Given this list of marker genes Cbfb, Dsg1a, Ap3s1, Ankfy1, Larp4, Fcho2, Nherf1, Celf3, BC005537, Zfc3h1, Cadm2, Myo6, Sema5b, Fam210a, Ears2, Sec23ip, Ero1b, Rprd1a, Ddx3x, Rwdd4a, Klhl29, Naaladl2, Tcf24, Tmem154, Pira2, Col8a2, Slc2a13, Pik3r1, Fam120a, Rnf152, Depdc5, Gsdmc, Bcl11b, Agfg1, Dipk2b, Tmx1, Tob1, Nup85, 2310002L09Rik, C9orf72, Prdm15, Leap2, Traf6, Inpp4a, Rab10, Zfp872, Tent5a (NCBI Gene Id 320335), Ovol1, Med13, Pank3, Cnot6, Fat4, B4galt4, Cd300a, Daam1, Nanog, Rbm27, Gm7694 (predicted gene 7694), Asxl2, Impa1, Cdk6, Slco1a1, Deptor, Pcmtd2, Inpp4b, Mknk2 (MAP kinase-interacting serine/threonine kinase 2), Ptpdc1, Fuca2, Dcaf12l2, Kcnd3, Strip2, Ttll1, Sema3e, Alg5, Sgms1, Dok5, Fbxo38, Hoxd1, Psen2, Cd53, Ppp4r2, Mterf1b, Homez, Phactr2, Zmynd8 (NCBI Gene Id 99150), Xrn1, Tacc1, Ino80d, Impg1, Pde10a, Bmerb1, Nckap5, Rab35, Mpv17l, Asap2, Wnt11, Ubl3, Bbx, Eif5a2, Nr2f6, Phykpl, Krt12, Chordc1, Tnrc6c, Lcp2, Smg1, Idnk, Arhgap36, Mycs, Ramac, Klhl42, Tram1l1, Dlst, Lrba, Bnc1, Abhd13, Oprk1, Rfesd, Fcrla, Runx2, Hmbox1, Uqcc6, Dpysl2, S1pr1, Usp54, Zfp143, Pikfyve, Nolc1, Slc4a2 (NCBI Gene Id 20535), Rgs7bp, Clcn4, Zfx, Nt5e, Nfrkb, Ipmk, Elovl5, Zfp800, Tmem131, Gspt1, Pigv, Dcun1d5, Iqgap2, Slc27a2, Tmem33, Mcf2l, Mak, A130010J15Rik, Krtap19-3, Phf11d, Smad2, Phf3, Rhobtb3 (Rho-related BTB domain containing 3), Slc35f5, Rnf150, Ints2, Fut9, Tmem150c, Trp63, Zbtb41, Ikbip, Rb1cc1, Shld2 (NCBI Gene Id 75698), Cntn2, Srsf1, Zfp704, B3gnt5, Dennd1b, Hnrnph2, Secisbp2l, Tfr2 (NCBI Gene Id 50765), Ripor2, Lpin2, 3110040N11Rik, Zfp365, Mmut, Senp7 (SUMO1/sentrin specific peptidase 7), Slc40a1, Itgb6, Bach1, Tenm4, Rock1, Ppp3r2, Pak2, Kmt2d, Shoc2, Dicer1, Atad2b (ATPase family, AAA domain containing 2B), Irs4, Prtg, Golga4 (golgin A4), Iqgap1, Setbp1, St18, Rrp1b, Pdcd4, Crppa, Trim33, Foxn2, Tyw5, Homer1, Ndfip2, Stx17, Nucks1, Epm2aip1, Sertad2, Ctnnd1, Nlrp4c, Sun1, Onecut2, Galntl6, Snx10, Nsd2, Slitrk2, Snx12, Zfp654, 3110082I17Rik, Brd8, Sp1, Mettl17, Sec23a, Itpr1, Hus1, Stom, Usp28, Hsf2bp, Fmr1, Ppm1b, Ikzf2, Cotl1, Tmcc3, Ankle2, Ptchd1, Arhgef6, Agtpbp1 (NCBI Gene Id 76578), Grxcr1, Gpr155, Fam169a (family with sequence similarity 169, member A), Hs3st3a1, Lpgat1, Cdc42bpa, Birc3, Tnfrsf11b, Prkci, Oprm1 (NCBI Gene Id 18390), Ctps2, Il13 (interleukin 13), Zfp518a, Grk2, Nufip2, Fzd3, Npat, Txndc5, Zxdc, Rabgap1l, Dgki, Olfm1, Sgip1, Nprl3, Zbtb5, Errfi1, Tnrc6b, Kat6a, Mbd4, Bicd1, Ngf, Zfp131, Fubp1, Sar1a, Mob3b, Steap2 (six transmembrane epithelial antigen of prostate 2), Bmt2, Sirt1, Cnot2, Phc3, Atxn7, Ubfd1, Braf, Tgoln1, Lrrfip1, Cdkn1b, Rxfp2, Rc3h2 (ring finger and CCCH-type zinc finger domains 2), Phf20l1, Phka1, Fgfbp3, Dmrt2 (doublesex and mab-3 related transcription factor 2), Rbpj, Map2, Lurap1l, Foxg1 (forkhead box G1), Zfand4, Ptbp1, Perp, Manea, Itpripl2, Trip11, Pbx4, Ankrd7, Enah, Tead1, Fkbp14 (NCBI Gene Id 231997), Cbx6, Bcor, Zranb2 (NCBI Gene Id 99569), Col25a1, Psd3, Rbp3, Gphn, Tgfa (NCBI Gene Id 21802), Tent4b (NCBI Gene Id 70570), Kalrn, Cdc14b, Ctsc, Acadl, Vgll3, Ehmt1, Htr1f, Potegl, Dytn (dystrotelin), Ereg, Mos, Grb2, Trim24, Adam22, Tmem200c, Smad6, Rapgef6, Ccdc157, Myc, Atp2b4, Fgf10, Ccr1, Mex3b, Nbr1, Trmt1l, Rgs6 (regulator of G-protein signaling 6), Sapcd2, Or51e2, Zbtb24, Rsrp1, Frmd3, Plppr5, Gtf2h1, Mafk, 1700102P08Rik, Aggf1 (angiogenic factor with G patch and FHA domains 1), Mdga2, Prpf4b, Rfx3, Ncor1, Acbd5, Pcmtd1, Grm1, Tbx22, Nsmce4a, Gtf2a1, Dach1, Zic2, Phip, Cxcl9, Gm14322, Sephs1, Mblac2, Reps2, Nup54, Chrna1, Ncl (nucleolin), Slc25a51, Setd3, Ninl, Bmi1, Slmap, Pttg1, Rora, Tbl1xr1, Hlf, Cul4b, Clns1a, Tmem121, Fabp4, Glis3, Maf, Rgs12, Septin2, Yipf4, Dclk3, Zic3, Pabir2, Ttc14, Ctbp1, Atp12a, 1700066M21Rik, Rcsd1, Urb1, Them6, Arhgap26, Rybp, Cntrl (centriolin), Lats1, Tmem185b, Ppp2r5c, Cxcl2, Hmx2, Lsm5, Gabrg1, Prkar1a, Usp9x, Fndc3a, Yes1, Nin, Ctdspl2, Kpna1, Znrf3, Atp6v1c1, Mxi1, Lrp2bp (Lrp2 binding protein), Zfp105 (zinc finger protein 105), Tnfsf15, Ablim1, Tpst2, Mbnl2 (muscleblind like splicing factor 2), Kif2a, Ube2r2, Akap11, Lnx1, Sh3rf1, Stap1, Slc31a1, Frmd5, Fermt2, Mmd, Inip, Rab15, Hoxb3, Elk3 (ELK3, member of ETS oncogene family), Kcnj2 (potassium inwardly-rectifying channel, subfamily J, member 2), Gpr180, Kdm4c (lysine (K)-specific demethylase 4C), Rbm47, Dnal1, Zmynd11, Vcl, Adam10, Rnasek, Ildr2, Agmo, Il1a, Mical3, Crim1, Grk6, Plxnc1, Aak1, Syne2, Pcsk5, Hdac2, Otud7b, Pum2, Cpox, Mrps24, Ank3, Irs1, Col5a2, Ralb, Nufip1, Tafa2, Strbp, Fsd1l, Atp10a, Pard3b, Mysm1, Lrrc4, Lmln, Mgat5b, Stx2, Pdcd10, Herpud2, Klhdc10, D16Ertd472e, Rab27b (NCBI Gene Id 80718), Rnf168, Gdi2, Mllt10, Dsg1b, Mctp1, Ankrd44, Pth, Atg3, Nptx2, Tmem196, Crybg3, Angpt1, Tmed7, Mbnl3, Slc12a2, Sspn, Jph1, Atl2, Erbb2, Ccdc65, Ypel1, Rapgef2, Gpat3, Plppr4, Enoph1, Lin28b, Umad1, Marcks, Ergic2, Ikzf4, Celf2, Plekhd1, Zc3h12c, Klf12, Dio2 (deiodinase, iodothyronine, type II), Serbp1 (NCBI Gene Id 66870), Nav2, Srsf6, Cask, Wtap, Trpc4ap, Pmepa1, Ppm1d, Cenpl, Camk4 (calcium/calmodulin-dependent protein kinase IV), Klhl2, Rnf138, Pabpn1l, Pilra, Kdsr, Sox6, Cpsf6 (NCBI Gene Id 66698), Mme, Bbs5, Zzz3, Dpf2, Lif, Acvr2b, Sema3d, Tspyl1, Fbxw11, Nras, Bloc1s6, Ppp2r5e, Htatsf1, Kcnb2, Kdm7a, Slc12a8, Dtwd2, Ank, Tfdp1, Rfk, Mybl1, Mef2a, Taok1, Stxbp5l, Atp2c1, Slc10a2, Scyl2, Mbtps2, Zfp383, Zeb2, Ppil3, Setx, Zfp217, Rims2, Lrrn1, Vezt, Erlec1, Rnf2, Adra1b, Rap2b, Atp2b3, Rsf1, St8sia1, Sgms2, C130074G19Rik, Ramacl, Chd1, Tmem117, Negr1, Cd2ap, Mrc2, Kcnv1, Tmed8, Stk26, Fam118a, Depdc1a, Ikzf5, Tle4 (NCBI Gene Id 70490), Bicral, Sptlc2, Ankrd13c, Kansl1l, Luzp1, Tiam2, Map1b, Wdr89, Cblb, Cstf3, Adgrg2, Miga1, Cdh11, Lbh, Zcchc8, Ppp1r15b, Rhpn2, Neil3, Foxo4, Ubtd2, Atp1b4, Zfand5, Limk2, Pds5b, Nfxl1, Foxk2, Usp42, Fsbp, Pakap, Sox9, Dmxl1, Cab39l (calcium binding protein 39-like), Ptprb, Ptprj, Gpm6b, Gnb1, B4galt7, Atp6v0a2, Dhx15, Foxd2, Tmeff1, Arhgap18, Csf3, Wdr12, B3galnt2, Ccdc73, Unk, Plagl1, Ythdc2, Arl16, Pcnx1, Etl4, Scai, Srpk2, Gabpa, Gng2, Spred1, Usf1, Rubcnl, Sowahc, Sntg1, Samd5, Bend7, Zfp318, Zfp507, Zfp248, Arih1, Lpar1, Zfhx3, Dock3, Lsm14a, Actr10, Slc39a9, Crebzf, Ing1 (inhibitor of growth family, member 1), Creb5, Tmem170, Ptprg, Amigo2, Sowaha, Ccp110, Ift70a1, Tal1, Tgfbr3, Sptssb, Zbtb44, Agps, Cyfip2, Msi2, Celf1, Dusp7, Rnaseh2a, Phf20, Hnrnpul2, Kdm6a (lysine (K)-specific demethylase 6A), Acp2, Smim7, Afap1l2, Klhl23, Meioc, Ntn1, Ube2w (NCBI Gene Id 66799), Anks1b, Fbxo11, Resf1, Hormad1, Ptger4, Carf, Ccdc18, Psma1, Phex, Satb1, Mon2, Ccdc14, Elp4 (elongator acetyltransferase complex subunit 4), Raph1, S100pbp, Nf1, Fhip2a, Ube2k, Gabra4, Trabd2b, Zdbf2, Ctdspl, Nus1, Pclo, Trim13 (tripartite motif-containing 13), Morc2b, Rasa1, Rc3h1, Pla2r1, Kif18a, Brd1, Cntn4, Il1rapl2, Scfd1, Nexmif, Cmc2 (NCBI Gene Id 68811), Birc6, Septin11, Lrrc39, Col11a2, Pdxdc1, Gli3, Esco1, Cpeb3, Pogz, Rab8b, Aasdhppt, Nbeal1, Ppp4r4, Ppp1cb, Akr1d1, Pym1, Dot1l, Pnrc2, Dazl, Tfap2b, Pdlim5, Emx2, 5730507C01Rik, Apba3 (amyloid beta precursor protein binding family A member 3), Commd7, Tmem47, Paip1, Nfyb, Aebp2, Kdm1b, Spryd7, Ampd3, Ppp1ca, Rab11fip2 (NCBI Gene Id 74998), Wdr43, Kcnk2, Slc8a1, Tcaim, Nsrp1, Ppme1, Gsk3b, here is a description of the gene set: Mouse Gene Set: MIR_3094_3P Genes predicted to be targets of miRBase v22 microRNA mmu_miR_3094_3p in miRDB v6.0 with MirTarget v4 prediction scores > 80 (high confidence targets). species: Mus musculus from publication Chen Y, Wang X (PMID 31504780)